The following is a description of a gene set: from publication Pastural E, Takahashi N, Dong WF, Bainbridge M, Hull A, Pearson D, Huang S, Lowsky R, DeCoteau JF, Geyer CR (PMID 16953217) Human Gene Set: PASTURAL_RIZ1_TARGETS_UP Genes up-regulated in K562 (chronic myelogenous leukemia, CML) cells engineered to stably express RIZ1. RIZ1 is a histone methyltransferase whose expression and activity are reduced in many cancers. In chronic myelogenous leukemia (CML), blastic transformation is associated with loss of heterozygosity in the region where RIZ1 is located and with decreased RIZ1 expression. Forced RIZ1 expression in model CML blast crisis (BC) cell lines decreases proliferation, increases apoptosis and enhances differentiation. We characterized molecular mechanisms that may contribute to potential CML tumor suppressor properties of RIZ1. Several RIZ1-regulated genes involved in insulin-like growth factor-1 (IGF-1) signaling were identified using cDNA microarrays. RIZ1 was shown to associate with promoter regions of IGF-1 and to increase histone H3 lysine 9 methylation using chromatin immunoprecipitation assays. IGF-1-blocking antibody was used to demonstrate the importance of autocrine IGF-1 signaling in CML-BC cell line viability. Forced RIZ1 expression in CML-BC cell lines decreases IGF-1 receptor activation and activation of downstream signaling components extracellular signal-regulated kinase 1/2 and AKT. These results highlight the therapeutic potential of inhibiting IGF-1 pathway in the acute phase of CML. studied in species Homo sapiens, and this is the list of marker genes: SPARC, RFESD, HLA-E, CLIC2, PLIN2, LIMS1, HEMGN, ENPP3, LRRC61, FGF13